Given this list of marker genes Spesp1, Sppl2c, Gnpda1, Adcy3, Gm773, Hvcn1, Fam170b, Spink1, Prss37, Pla2g10, Trim36, Spink13, Rims1, Iqcf1, Lcn6, Pkdrej, Syt6, Frey1, Prnd, Eqtn, Acr, Stxbp1, Syt8, Pcsk4 (proprotein convertase subtilisin/kexin type 4), Cacna1h, B4galt1, Garin1b, Glipr1l1, Unc13b, Plb1, Trpc2, Stx2, Iftap, Tnp2, Ccdc87, Zp3, Hyal3, Glra1, Abhd2, Rab3a, Plcb1, Crisp4, Glrb, Plcd4, here is a description of the gene set: species: Mus musculus Mouse Gene Set: GOBP_ACROSOME_REACTION The discharge, by sperm, of a single, anterior secretory granule following the sperm's attachment to the zona pellucida of the oocyte. The process begins with the fusion of the outer acrosomal membrane with the sperm plasma membrane and ends with the exocytosis of the acrosomal contents into the zona pellucida.